The following is a description of a gene set: Mouse Gene Set: MIR_7647_5P Genes predicted to be targets of miRBase v22 microRNA mmu_miR_7647_5p in miRDB v6.0 with MirTarget v4 prediction scores > 80 (high confidence targets). species: Mus musculus from publication Chen Y, Wang X (PMID 31504780), and this is the list of marker genes: Shisa6, Frzb, Gk5, Ebf3, Topors, Hnrnpf, Bmp2k, Xiap, Rnf216 (ring finger protein 216), Scaf11, Mtpn, Nkain2, Cir1, Hoxb8, Asb15, Ppp2r2a, Pdc, Taf2, Eri2, Vapa, Sypl1, Hsd17b3, Mterf2, Ell2 (elongation factor for RNA polymerase II 2), Lrrn1, Ammecr1, Pip4p2, Akirin2, Clock, Rspry1, Acadsb, Crebzf, Dbn1, Nr4a2, Rrm2b, Msi2, Ubqln1, Ttn